The following is a description of a gene set: studied in species Mus musculus part of: Signaling by Interleukins electronically inferred by orthology from the curated human pathway This event has been computationally inferred from an event that has been demonstrated in another species.<p>The inference is based on the homology mapping from PANTHER. Briefly, reactions for which all involved PhysicalEntities (in input, output and catalyst) have a mapped orthologue/paralogue (for complexes at least 75% of components must have a mapping) are inferred to the other species. Reactome Pathway: Other interleukin signaling, and this is the list of marker genes: Csf1r, Stx1a, Stx4a, Vamp2, Sdc1, Casp3, Il34, Stx3, Il16